The following is a description of a gene set: Mouse Gene Set: GOBP_POST_GOLGI_VESICLE_MEDIATED_TRANSPORT studied in species Mus musculus The directed movement of substances from the Golgi to other parts of the cell, including organelles and the plasma membrane, mediated by small transport vesicles., and this is the list of marker genes: Plcb3, Golph3, Prepl, Vamp2, Steap2 (six transmembrane epithelial antigen of prostate 2), Lypla1, Ap3s1, Amn (NCBI Gene Id 93835), Arl3, Kif16b, Kif13a, Vti1b, Phaf1, Nsf, Gga3, Exoc8, Rab11fip3, Lyplal1, Rbsn, Lamp1, Vps35l, Scfd1, Rab13, Exoc5, Krt18, Pkdcc, Wipi1 (NCBI Gene Id 74799), Blzf1, Chic2, Cnst, Dop1b, Dnm2, Vps54, Eps15, Golga7, Arfgef2, Ccdc93, Gga1, Myo5a, Laptm5, Gbf1, Ank3, Exoc1, Commd1, Sec16a, Rab31, Rabif (RAB interacting factor, NCBI Gene Id 98710), Macf1, Nbea (NCBI Gene Id 26422), Ccdc91, Ap1ar, Sys1, Acsl3, Myo1b, Vamp5, Sptbn1, Sorl1, Optn (optineurin), Golga4, Ap1g1, Ap4m1, Vps29, Llgl1, Bbs2, Exoc6, Rab26, Mon2, Vamp4, Gak, Stxbp5, Cln3, Dop1a, Rab34, Ehd3, Stxbp5l, Ap3s2, Bbs1, Csk, Slc30a6, Vps52, Rack1 (NCBI Gene Id 14694), Coro7, Rabep1, Klhl20 (kelch-like 20), Ankfy1, Rab10, Sort1, Exoc4, Atp2c1, Arfrp1, Ap3d1, Ap1g2, Sorcs1, Ccdc22, Llgl2, Golph3l, Exoc6b, Vti1a, Exoc2, Vamp3, Rp2, Rab14, Gga2